Given this list of marker genes MAN1B1, EDEM3, RNF139, UGGT1, EDEM1, RNF103, EDEM2, MAN2B1, AGA, MAN1A1, MAN1C1, UGGT2, RNF5, AMFR, MAN1A2 (mannosidase alpha class 1A member 2), TRIM13, RNF185, OGA (NCBI Gene Id 23375), MARCHF6, SYVN1, here is a description of the gene set: studied in species Homo sapiens The removal of sugar residues from a glycosylated protein. Human Gene Set: GOBP_PROTEIN_DEGLYCOSYLATION